The following is a description of a gene set: Any process that stops, prevents, or reduces the frequency, rate, or extent of interleukin-2 production. species: Mus musculus Mouse Gene Set: GOBP_NEGATIVE_REGULATION_OF_INTERLEUKIN_2_PRODUCTION, and this is the list of marker genes: Tnfaip3, Ptprc, Prnp, Ezr, Cd34 (NCBI Gene Id 98592), Sftpd, Homer2, Cd276, Lilrb4a, Zfp36, Homer3, Vsig4, Laptm5, Gpr174, Nr1h4, Trim27, Il20rb, Havcr2, Lag3, Gata3, Lilrb4b, Xcl1, Tbx21, Foxp3, Kat5, Nod2, Nav3, Hdac7